The following is a description of a gene set: Negative epigenetic regulation of rRNA expression Human Gene Set: REACTOME_NEGATIVE_EPIGENETIC_REGULATION_OF_RRNA_EXPRESSION species: Homo sapiens, and this is the list of marker genes: H2AC7, TAF1C, H4C16, H2BC14, H3C4, SAP30BP, CDK7, H3-3A, POLR1G, POLR2K, H2BC9, H3C7, SAP130, H4C5, H2BC26, CCNH, H4C1, H2AZ2, H2BC5, SIRT1, H3C1, H2BC17, H3-3B, GTF2H4, SIN3A, SAP30L, H2BC12, ERCC2, H2AC14, ERCC3, POLR1E, MNAT1, SAP30 (Sin3A associated protein 30), H2BC6, ARID4B, H4C9, SUV39H1, SAP18, GTF2H2, GTF2H3, H3C11, H2BC3, H2AC18, SMARCA5, H2BC11, H2BC4, H2BC21, H4C4, DNMT3B, H2AC20, H4C8, POLR2F, POLR1F, H3C14, POLR1C, H2AC8, GTF2H1, DNMT1, H4C15 (NCBI Gene Id 724021), POLR2H, H2AX, H3C8, H3C3, POLR1H, H2BC7, H2BC15, H2AJ, H2BC12L, H3C15, POLR1B, H2AC19, GTF2H5, H2BC10, H2BC8, H4C2, H2AC6, H2BC13, RRP8, H3C2, TAF1B, H3C10, POLR2L, H3C6, TAF1A, H4C11, SUDS3, H3C13, H3C12, HDAC1, POLR1A, TBP, TAF1D, H2BC1, H4C14 (NCBI Gene Id 8370), H4C13, SIN3B, UBTF, POLR1D, POLR2E, MBD2, H4C3, H4C6, H4C12, TTF1, H2AB1, HDAC2, H2AC4, BAZ2A